Given this list of marker genes ERH, ALOX5 (NCBI Gene Id 240), EXOC1, ZNF394, PMS2P1, YWHAH (NCBI Gene Id 7533), MLEC, CSRP1 (cysteine and glycine rich protein 1), TTK, RXYLT1, OTUB1, KIFBP (kinesin family binding protein), OTULINL, PPOX, MOCS1, ZNF665, PREB, ETFDH, BORCS6, PAAF1, WRAP73 (WD repeat containing, antisense to TP73), MOGS, CRAT, HPS1, SNUPN, CAND1, EHMT2, NVL, UBR7, GGA2, FTO, PSMD9 (proteasome 26S subunit, non-ATPase 9), DOP1B, ELAVL1, CDK19, PTTG1, TUBG1, PPCS, SLCO3A1, GAS2L1, ARHGEF18, SYNCRIP, GLMN, ELAVL4, TCTA, RBBP5, HS1BP3 (NCBI Gene Id 64342), CD164, BAZ1B, CPPED1, NUP133, GPKOW, AVEN, LBHD1, TUFT1, DPF2, SDF2L1, FBXO21, TP53, ZNF14, TBC1D13, C17orf75, CTDSP1, BNIP3L, MTHFD1, ORC4, MPI, XPO7, CPEB1, MIEF1, BMAL1, AKAP1, ANKRD27, OARD1, PEX14, WDR25, PLEKHA1, NOL6, BRD3OS, RNF8, PIP4K2C, ZNF682, SUPT20H, BAG2, TCFL5, HILPDA, FAM136A, MAP3K1, ZNF180, TTBK2, RHOG, DNASE2, TDRD3, ACAD8, MTRR, RSAD1, OSER1, EFNA3, JUP, FXR1, LRRC14, COA3, BBS4, ATIC, ELOA-AS1, FBXO38, GGPS1, PPM1H, RPA3, C21orf91, MEGF9, TNFAIP8, PSMB1, GPSM2, NUDC, TBC1D31, HIRA, PA2G4, EI24, FES, PIK3R3, GOLPH3L, ARFIP1, AAGAB, BAZ2B, PTPN18, CCNB2, SLC30A6, NAA16, H2BC4 (NCBI Gene Id 8347), ACTMAP, GIGYF2, RAB11FIP4, SSRP1, BTK, SMC3, TRIM24, KIAA0513, YIPF1, SLC35A1, DNAJC22, PEX3, ZDHHC4, EIF2B1, TST, ARHGEF6, CEP192, YTHDC2, FN3KRP, HPS6, PAGR1, SLC38A10, TMEM115, FNTA, CPT2, TCAF1, PTER, IMPACT, ZNF646, CTCF, PCYOX1L, BBX, DCAF7, TCF15, SREK1IP1, DLAT, SET, GDI2, MED16, SUPT7L, CENPC (centromere protein C), INTS5, NDRG2, GFUS, NAT9, FAM200C, TRMT1L, EED, CSE1L, GNL3, CYP2E1, EBAG9, ATP5PD, SCP2, MIS18A, MCM9, CLUAP1, C19orf53, TELO2, DNPEP, NCBP1, CPNE1, ESYT1, GRIN2C, GALNT10, BARD1, HADHA, SLC25A28, ZFTA, FHL1, here is a description of the gene set: from publication Baker DA, Barth J, Chang R, Obeid LM, Gilkeson GS (PMID 20644167) Human Gene Set: GSE20152_SPHK1_KO_VS_WT_HTNFA_OVERXPRESS_ANKLE_DN studied in species Homo sapiens Genes down-regulated in ankle joints over-expressing TNF: SPHK1 knockout versus wildtype. The study analyzes analyzes gene expression changes in the ankle joint in mouse TNFa overexpression models with or without sphingosine kinase 1 activity. SphK1 is a sphingolipid enzyme that converts sphingosine to bioactive sphingosine-1-phosphate (S1P). Recent data suggest a potential relationship between SphK1 and TNFα and have implicated SphK1/S1P in the development and progression of inflammation. Here we further study the relationship of TNFα and SphK1 using an in vivo model. Transgenic hTNFα mice, which develop a spontaneous arthritis (limited to paws) at 20 weeks, were crossed with SphK1 activity null mice (SphK1-/-) to study the development of inflammatory arthritis in the functional absence of SphK1. Results show that hTNF/SphK1-/- have significantly less severity and progression of arthritis and bone erosions as measured through micro-CT images. Additionally, less COX-2 protein, mTNFα transcript levels and fewer Th 17 cells were detected in the joints of hTNF/SphK1-/- compared to hTNF/SphK1+/+ mice. Microarray analysis of the ankle joint showed that hTNF/SphK1-/- mice have increased transcript levels of IL-6 and SOCS3 compared to hTNF/SphK1+/+ mice. Finally, fewer mature osteoclasts were detected in the ankle joints of hTNF/SphK1-/- mice compared to hTNF/SphK1+/+ mice. These data show that SphK1 plays a role in hTNFα induced inflammatory arthritis, potentially through a novel pathway involving IL-6 and SOCS3.